The following is a description of a gene set: Up-regulated genes in hepatocellular carcinoma (HCC) subclass G123, defined by unsupervised clustering. Hepatocellular carcinomas (HCCs) are a heterogeneous group of tumors that differ in risk factors and genetic alterations. We further investigated transcriptome-genotype-phenotype correlations in HCC. Global transcriptome analyses were performed on 57 HCCs and 3 hepatocellular adenomas and validated by quantitative RT-PCR using 63 additional HCCs. We determined loss of heterozygosity, gene mutations, promoter methylation of CDH1 and CDKN2A, and HBV DNA copy number for each tumor. Unsupervised transcriptome analysis identified 6 robust subgroups of HCC (G1-G6) associated with clinical and genetic characteristics. G1 tumors were associated with low copy number of HBV and overexpression of genes expressed in fetal liver and controlled by parental imprinting. G2 included HCCs infected with a high copy number of HBV and mutations in PIK3CA and TP53. In these first groups, we detected specific activation of the AKT pathway. G3 tumors were typified by mutation of TP53 and overexpression of genes controlling the cell cycle. G4 was a heterogeneous subgroup of tumors including TCF1-mutated hepatocellular adenomas and carcinomas. G5 and G6 were strongly related to beta-catenin mutations that lead to Wnt pathway activation; in particular, G6 tumors were characterized by satellite nodules, higher activation of the Wnt pathway, and E-cadherin underexpression. CONCLUSION: These results have furthered our understanding of the genetic diversity of human HCC and have provided specific identifiers for classifying tumors. In addition, our classification has potential therapeutic implications because 50% of the tumors were related to WNT or AKT pathway activation, which potentially could be targeted by specific inhibiting therapies. studied in species Homo sapiens Human Gene Set: BOYAULT_LIVER_CANCER_SUBCLASS_G123_UP from publication Boyault S, Rickman DS, de Reyniès A, Balabaud C, Rebouissou S, Jeannot E, Hérault A, Saric J, Belghiti J, Franco D, Bioulac-Sage P, Laurent-Puig P, Zucman-Rossi J (PMID 17187432), and this is the list of marker genes: CPSF6, PEG10, GINS1, PNMA1, RBM3, CAPRIN1, PON2, ATAD2, PRKCI, TMPO, SAC3D1, SNRPE, HAT1, KIF20A, CD24P2, SHC1, TUFT1, POGK, CPD (carboxypeptidase D), SMC4, PRKDC, CD24, ENAH, RFC4, SNRPD1, CCNB2, MAP4K3, CD24P4, SUCO, ISG20L2, CCT3, ACLY, DUSP12, MRPL9, NT5DC2, LARP4B, CKAP4, SNRPB, VIL1, CACYBP, PLCB1, SGCE, BARD1, CBX1 (chromobox 1), UBAP2L, KPNA2 (NCBI Gene Id 728860), FABP5